Given this list of marker genes LGALS9, LGALS1, LGALS12, LGALS3, LGALS16, here is a description of the gene set: Binding to a disaccharide. Disaccharides are sugars composed of two monosaccharide units. species: Homo sapiens Human Gene Set: GOMF_DISACCHARIDE_BINDING